The following is a description of a gene set: species: Homo sapiens Human Gene Set: GOBP_TRACHEA_DEVELOPMENT The process whose specific outcome is the progression of a trachea over time, from its formation to the mature structure. The trachea is the portion of the airway that attaches to the bronchi as it branches., and this is the list of marker genes: HOXA5, MAP2K2, MAPK1, EDA, WNT7B, RARG, MAP2K1, MAPK3, RARA, LEF1, SRF, FOXF1, CTNNB1, SHH, RSPO2, HYDIN, BMP4 (NCBI Gene Id 652), SOX9, TGFBR2